The following is a description of a gene set: Human Gene Set: GOMF_DIPEPTIDYL_PEPTIDASE_ACTIVITY studied in species Homo sapiens Catalysis of the hydrolysis of N-terminal dipeptides from a polypeptide chain., and this is the list of marker genes: DPP7, DPP4, DPP3, CTSC, PRCP, DPP9, DPP10, PRSS16, NAALAD2, FAP, DPP6, DPP8